Given this list of marker genes GSTM2, RYR3, SELENON (NCBI Gene Id 7800), CASQ2, TMEM38A, RYR1, TMEM38B, CACNA1S, SLC8A1, RYR2, TRPA1, here is a description of the gene set: species: Homo sapiens Any process that results in a change in state or activity of a cell (in terms of movement, secretion, enzyme production, gene expression, etc.) as a result of a caffeine stimulus. Caffeine is an alkaloid found in numerous plant species, where it acts as a natural pesticide that paralyzes and kills certain insects feeding upon them. Human Gene Set: GOBP_CELLULAR_RESPONSE_TO_CAFFEINE